The following is a description of a gene set: Mouse Gene Set: GOBP_REGULATION_OF_REGULATED_SECRETORY_PATHWAY species: Mus musculus Any process that modulates the frequency, rate or extent of regulated secretory pathway., and this is the list of marker genes: Atp2a2, Kcnh1, Itgam, Scamp5, Stxbp3, P2rx2, Syt3, Ceacam1, Il13, Htr1b, Wnt7a, Ncs1, Adora2b, Cd160, Syt4, Gata2, Dtnbp1, F2rl1, Itgb2l, Rab5a, Rab15, Fbxl20, Trim9, Ptafr, Syt2, Baiap3, P2rx1, P2ry2, Syt8, Syt17, Tprg1l, Gata1, Crhr1, Syt9, Syt1, Cacna1i, Pla2g3, Prkcb, Itgb2, Rabgef1, Snx4, Rph3a, Ap1g1, Cspg5, Gnai2, Syt15, Syk, Rab3d, Fgr, Cacna1d, Pram1, Sv2c, Bcl2l1, Hmox1, Fcer1a, P2ry4, Htr1d, Rap1a, Rest, Git2, Rims2, Git1, Cdk5r2, Fmr1, Fbxo45, Foxf1, Doc2g, Vamp2, Syn1, Cd300a (NCBI Gene Id 217303), Nlgn1, Lamp1, Lgals9, Syt13, Npy, Stx1a, Nckap1l, Braf, Syt10, Pdpk1, Syt7, Fcer1g, Lypd10, Il4, Hyal3, Prkca, Syt5, Abr, Rph3al, Vamp8, Rac2, Cacna1h, Vps18, Dvl1, Unc13b, Cd177 (CD177 antigen), Gab2, Stxbp1, Doc2b, Rab27a, Mical1, P2ry1, Prepl, Cbarp, Spi1, P2rx7, Rab3gap1, Cacna1a, Ppfia2, Ccr2 (C-C motif chemokine receptor 2), Il13ra2, D6Wsu163e, Cask, Rap1b, Gpr151, Snap29, Arf1, Rims4, Cacna1g, Rims3, Sphk2, Dnm1l, Syt12, Prkcg, Syt11, Pld2, Rims1, Cdk5, Nppa, Il4ra, Unc13d, Ms4a2, Npy1r, Notch1, Rab3a, Stx4a, Syt6, Doc2a, Snapin, Cd84, Adra2a, Cacna1e, Nppc, Stxbp2, Zp3, Pou5f1, Sv2b, Kcnb1, Stxbp5, Slc4a8, Adora3, Bcr, Lypd11, Lyn, Stxbp5l, Cacnb4, Fes, Pfn2, Cadps, Lrrk2